Given this list of marker genes ARHGEF3, ADM, B4GALT3, NIN, RBM22, TEX12, PI4K2B, SNORC, BATF2, SH3BP5, VWA7, BMAL2, RNFT1, C8orf82, PRELP, TACSTD2, PCBD2, SYN3, CAPN6, PAX7, P2RY14, HABP2, CD37, CD33, FGD6, SLC6A13, SLC25A25, TRAF3IP2, CDC25A (NCBI Gene Id 993), ABCD2, CNNM3, PITPNC1, HADHB, ACOT2, TNIP2, CARD19, COL6A3, MFN2, RAB21, CCL4, OASL, IRF9, C11orf96, TGM3, EIF3J, CLINT1, CRYBB3, ENTPD5, USP42, CCL2, IL18, SYNGR1, PDZD9, POU5F1, ZNF346, MYLIP, ACO1, SCGB3A1, BCL2L2, STAG3, TNFRSF4, TJP1, S100A1, EDN1, ATP6V1H, PPP1R15A, PHF7, IL6ST, GDF3, TNF, ARMCX2, LOXL3, NBN, HLA-DRB1, BEST2, AMMECR1, IRF2BP1, FGL2, ALAS2 (NCBI Gene Id 90735), MMP9, GET3, HAO2 (hydroxyacid oxidase 2), RNF157, CDCA5, POLR3A, CAPN3, NSMF, NARF, RAB6A, GABRA6 (gamma-aminobutyric acid type A receptor subunit alpha6), POLR1A, RRP15, RSPO1, MANSC1, CDC42BPA, RFX3, PLA2G1B, SLC25A39, SOWAHC, ATP8B2, POU4F3, TRAPPC12, FLVCR2, ASB12, IGF2BP1, DHRS7, EPB41L3, RNF185, ADAM21, ABCG8, LRP2, POLA2, ATP11A, IFIT2, PLP1, PLAU, INTS15, CACNA1A, BCL2, RELA, CAMKV, CD274, REG3A, FIS1 (fission, mitochondrial 1), SLC22A17, MADCAM1, CDO1, TRAF6, SUGP2, PDE6D, TECTB, NTHL1, ZNF202, POLR1B, EPS15L1, CUL4A, FKBPL, EGFL8, RGS3, ITPKB, APOB, DCAF8, SERPINB2, ZC3H8, ASF1A (NCBI Gene Id 25842), USP47, DAP3, TIRAP, TM6SF1, RRM2B, TPTE, SECISBP2L, POLL, PXN, TAF6, PLPP3, PFN1, UQCRC2, ADAM9, MEF2B, QPCTL, CNOT7, ARHGAP21, KRTAP4-12, RNF2, C6orf120, MOGAT1, NT5C, ICAM1, MFSD14A, BRCA1, TNFAIP2, PAK1, TXLNG, AMFR, EPPIN, TMPRSS3, LCP2, NXF1 (nuclear RNA export factor 1), ZNF593, IL1A, SAT1, B3GNT2, RSRP1, PRIM2, IVD, CCL13, ALOXE3, MAFF, PGAM1 (phosphoglycerate mutase 1), COPS6, PPL, RUNX3, AP3M2, CLASP2, EMP1, RPA3, FKBP3, DRAM2, KCTD12, here is a description of the gene set: Genes down-regulated in comparison of dendritic cells (DC) stimulated with Pam3Csk4 (TLR1/2 agonist) at 2 h versus DC cells stimulated with CpG DNA (TLR9 agonist) at 2 h. Human Gene Set: GSE17721_PAM3CSK4_VS_CPG_2H_BMDC_DN from publication Amit I, Garber M, Chevrier N, Leite AP, Donner Y, Eisenhaure T, Guttman M, Grenier JK, Li W, Zuk O, Schubert LA, Birditt B, Shay T, Goren A, Zhang X, Smith Z, Deering R, McDonald RC, Cabili M, Bernstein BE, Rinn JL, Meissner A, Root DE, Hacohen N, Regev A (PMID 19729616) species: Homo sapiens mouse primary BMDCs were stimulated with tlr ligands and gene expression changes were profiled on Affymetrix arrays